The following is a description of a gene set: species: Homo sapiens Any process that activates or increases the frequency, rate or extent of natural killer T cell activation. Human Gene Set: GOBP_POSITIVE_REGULATION_OF_NK_T_CELL_ACTIVATION, and this is the list of marker genes: IL12A, IL23R, IL12B, HSPH1, JAK2 (Janus kinase 2), IL18, TYK2, RASAL3, IL23A